The following is a description of a gene set: The process in which galactose is transported across a lipid bilayer, from one side of a membrane to the other. D-galactose is widely distributed in combined form in plants, animals and microorganisms as a constituent of oligo- and polysaccharides; it also occurs in galactolipids and as its glucoside in lactose and melibiose. Mouse Gene Set: GOBP_GALACTOSE_TRANSMEMBRANE_TRANSPORT studied in species Mus musculus, and this is the list of marker genes: Slc5a1, Slc2a8, Slc2a2, Slc45a1, Slc2a3